The following is a description of a gene set: Vitamin D3 (VD3, cholecalciferol) is a steroid hormone that principally plays roles in regulating intestinal calcium absorption and in bone metabolism. It is obtained from the diet and produced in the skin by photolysis of 7-dehydrocholesterol and released into the bloodstream. Very few foods (eg. oily fish, mushrooms exposed to sunlight and cod liver oil) are natural sources of vitamin D. A small number of countries in the world artificially fortify a few foods with vitamin D. The metabolites of vitamin D are carried in the circulation bound to a plasma protein called vitamin D binding protein (GC) (for review see Delanghe et al. 2015, Chun 2012). Vitamin D undergoes two subsequent hydroxylations to form the active form of the vitamin, 1-alpha, 25-dihydroxyvitamin D (1,25(OH)2D). The first hydroxylation takes place in the liver followed by subsequent transport to the kidney where the second hydroxylation takes place. 1,25(OH)2D acts by binding to nuclear vitamin D receptors and it has been estimated that upwards of genes are directly or indirectly regulated which are involved in calcium homeostasis, immune responses, cellular growth, differentiation and apoptosis. Inactivation of 1,25(OH)2D occurs via C23/C24 oxidation catalysed by cytochrome CYP24A1 enzyme. species: Homo sapiens Reactome Pathway: Vitamin D (calciferol) metabolism part of: Metabolism of steroids, and this is the list of marker genes: CUBN, UBE2I, VDR, LRP2, CYP27B1, LDLRAP1, GC, PIAS4, LGMN, CYP2R1, CYP24A1, SUMO2